Given this list of marker genes SLC30A5, PRSS23, LCK, CTCF, SYK, BNIP3L, GLRX, NDRG1, CCNL2, FLOT1, CEPT1, PDE3A, HLA-DQA1, GNPNAT1, NGF, SGCB, ARPC1B, TAF1C, HSD17B10, ITGB8, MARK3, TP53I11, EFNB1, SOX9, PDCD5, TBCA, SOD1, SOX7, ATP5ME, ZNF507, CTNND1, here is a description of the gene set: studied in species Homo sapiens Human environmental stress response genes not changed in primary fibroblasts from Werner syndrom (WS) patients in response to gamma radiation. from publication Kyng KJ, May A, Stevnsner T, Becker KG, Kølvrå S, Bohr VA (PMID 15897889) Human Gene Set: KYNG_ENVIRONMENTAL_STRESS_RESPONSE_NOT_BY_GAMMA_IN_WS The accumulation of DNA damage and mutations is considered a major cause of cancer and aging. While it is known that DNA damage can affect changes in gene expression, transcriptional regulation after DNA damage is poorly understood. We characterized the expression of genes in human primary fibroblasts after exposure to three different kinds of cellular stress that introduces DNA damage: 4-nitroquinoline-1-oxide (4NQO), gamma-irradiation, or UV-irradiation. Each type of stress elicited damage specific gene expression changes of up to 10-fold. A total of genes had similar changes in expression of 3-40-fold after all three kinds of stress. We examined transcription in cells from young and old individuals and from patients with Werner syndrome (WS), a segmental progeroid condition with a high incidence of cancer, and found various age-associated transcriptional changes depending upon the type of cellular stress. Compared to young individuals, both WS and old individuals had similarly aberrant transcriptional responses to gamma- and UV-irradiation, suggesting a role for Werner protein in stress-induced gene expression. Our results suggest that aberrant DNA damage-induced gene regulation may contribute to the aging process and the premature aging in WS.